The following is a description of a gene set: Amplified REL to transcription. Pathway ID: N00123. Pathway type: Variant. Pathway class: nt06240 Transcription. Pathway Definition from KEGG: REL* => (CCND2,BCL2A1,BIRC3,TRAF1,BCL2L1,CD86,CD40) Human Gene Set: KEGG_MEDICUS_VARIANT_AMPLIFIED_REL_TO_TRANSCRIPTION studied in species Homo sapiens, and this is the list of marker genes: REL, BIRC3, BCL2L1, CCND2, BCL2A1, CD86, TRAF1, CD40 (CD40 molecule)